The following is a description of a gene set: Human Gene Set: GOMF_PEPTIDE_BINDING Binding to a peptide, an organic compound comprising two or more amino acids linked by peptide bonds. species: Homo sapiens, and this is the list of marker genes: TRGV3, TRGV9, GRIA1, NMUR1, BRAP, NPY5R, LDLR, NUP58, ERAP2, OPRD1, ARMCX5-GPRASP2, APBB1, CRHBP, RANBP6, TRAV8-4, HLA-DQA2, HLA-DOA, PEX5, NUP153, MC3R, LILRB2, EPHB2, NFKBIA, GRIN1, POM121B, KDELR1, TNPO1, GRPR, LRPAP1, TRAV19, ADNP, PRNP, SLC7A5, SSTR5, HLA-DMB, SRP68, HSP90AB1, TOMM20L, FURIN (NCBI Gene Id 5123), SSTR4, POM121C, LDLRAD3, GRIN2B, GRIA4, RAMP3, LILRB1, APBA2, TGFB2, CACNA1A, GPR37, SLC7A8, TREM2 (triggering receptor expressed on myeloid cells 2), ENPEP, ITGAM, KDELR2, APBA3 (NCBI Gene Id 9546), TLR6 (NCBI Gene Id 10333), CLU, HLA-DPB1, NPY4R2, KPNA3, NPY4R, NPAP1, BACE1, HLA-DQB2, CABP1, CD74, NPEPPSP1, HLA-F, HFE, GRIA3, RXRA, TAP1, PTGDR2, SSTR1, C1QA, TAPBP, HLA-DMA, PPARG, GPRASP2, APOE, TRBV28, HLA-DQA1, HLA-C, ADCYAP1R1, PFDN5, TOMM22, CLEC4M, APBB2, GPR171, HLA-B, GSAP, SCARB1, IPO5, APBA1, HLA-DQB1, HLA-DPA1, RELA, PFDN6, KPNA2, PEX7, TMEM158, OPRM1, FZD5, FPR2, LRP8, PFDN4, TRAV23DV6, CD36, TOMM20, OPRK1, MSR1, FZD4, ATP1A3, ANPEP (NCBI Gene Id 290), POM121, HLA-DRB4, GRIA2, PGRMC1 (NCBI Gene Id 10857), PICALM, NUP98, HLA-DOB, SLC7A9, KPNB1, SORL1, NPR3, LDLRAP1, PRLHR, VBP1, GALR1, ITGB2, OPRL1, FZD6, TOMM70, AP2B1, NPBWR2, CALCR, ITM2B, IPO4, ITM2A, ITGA2, CLSTN1, COL25A1, KPNA6, PCSK5, MME, CLTB (NCBI Gene Id 1212), MAS1, DHCR24, TRAV12-1, PFDN2, ANG, TLR4, CD209, SRP54, CALR, FCGRT, RPS6KB2, NGFR, TNPO2, NPEPPS, CST3, BDKRB1, TIMM22, INSR, EPHA4, GPR149, NPY1R, HLA-H, CRIP1, SSTR2, HLA-DRB3, PFDN1, LNPEP, FBXO2 (NCBI Gene Id 4930), FNTB, SEC61A2, NLN, GRIN2A, PEX19, KPNA5, IAPP, NMUR2, KPNA1, NPY6R, TRAV12-2, ERAP1, MCHR1, CMKLR2, HLA-DRA, NUP214, TRHDE, CACNA1B, MRGPRX2, SRP14, TRBV7-9, BCHE, FCGR2B, BABAM2, B2M, HLA-DRB1, LRP1, GALR2, TLR2, TPP1, HLA-G (NCBI Gene Id 3135), CHRNA7, SEC61A1, SSTR3, PEX5L, KPNA7, ADRB2, MAPK8IP2, NPBWR1, TRAV12-3, HLA-DRB5, DLGAP3, NLRP6, KCNIP2, HSPG2, MARCO, CEMIP, TRBV12-3, ACHE, KDELR3, HLA-A, LILRB3, MAML1, HLA-E, NLGN1, KPNA4, ITM2C, TM2D1, LVRN, CRYAB, TUBB3, GPR37L1, CLTA, IDE, AP2M1, CMA1, APBB3, MC4R, AGER, POM121L2, TAP2, TRAV29DV5, KIR3DL1, APOA1